Given this list of marker genes PIM3, MUC16, EPPK1, ADAM22, UBLCP1, SLC9B2, GPAM, MAPRE2, ATG3, PDPK1, SPRY4, GPR89B, S100A1, PJA2, PGAP1, CCND2, IZUMO1R, CYP11A1, GPM6B, SRSF12, FKBP7, GTF3C6, ZIM2, HSD17B7, SNTA1 (NCBI Gene Id 6640, syntrophin alpha 1), ABRAXAS2, IQCF1, GFI1, DMAC2L, MDH1, COPS7B, C4B, GPR22, NRIP3, MED7, SUCLG1, ERGIC2, DAD1, SLC36A4, TFAP2E, SOCS4, DMRTA2, IL31, JAM3, SLC38A10, RBP4, CEBPA, TMPRSS11E, TRPC6, AFP, ADAMTSL3, AKAP7, CPEB1, ALDH16A1, TMPRSS15 (NCBI Gene Id 5651), CCDC3, DAAM1, KYAT3, GATA3, APOBR, SWI5, MSANTD3, SERPINB9 (serpin family B member 9), MOAP1, CACNA1A, CEACAM20, SLC23A2 (NCBI Gene Id 9962), HSBP1, MLLT11, FAM167B, ZNF862, PRKCA, WDFY2, ARL5A, ZNF707, GBA1, CWC25, PPIC, SAMSN1, FTCD, OTOP2, ZNF169, SUGCT, MEX3B, ACBD7, RPL10, PRADC1, AQP9, TMT1B, ZFP2, TTC9C, ITGB3, PCDHA12, CST7, PIGT, TMCC1, TRPA1, NDFIP1, RDH10, ABHD17C, TMEM150A, LAMA5, ALDH1A1, PDGFD, TLCD3B, PSMD10, MTSS2, BABAM2, CLCA2, ASPRV1, NMNAT2, PRPSAP2, CDKN2C, CASKIN2, ZNF260, UMAD1, CD200R1, KANK1, ROCK2, SLC45A1, RAB9A, CCDC33, ATOH8, ARHGAP5, ASB2, SCAMP5, ASTN2, NLRP9, TFAP2A, JAG1, CGA, FERRY3, CACNG6, AOX1, CAB39, PEPD, RTN4, OPN1SW, NDUFA4L2, TTLL13 (NCBI Gene Id 440307), HNRNPH3, ARFGEF2, TENT5A, ADGRA3, CNR2 (NCBI Gene Id 1269), SRSF1, ZFYVE16, ETFB, LPIN2, ECM1 (NCBI Gene Id 1893), BMP2, MTMR6, CALCR, PLRG1, TFB1M, RNF152, C6orf89, PLXDC2, FAM156A, COG2, MMP15, CCDC117, TPD52L1, CD300LD, SH3RF3, PLCXD3 (phosphatidylinositol specific phospholipase C X domain containing 3), LCORL, HSD11B2, LAMP1, MUC20, GPR87, CSF1, PRAP1, HS3ST6, CEP128, NUDCD1, C9orf85, RIOK3, ZBTB24, NTS, IGSF1, GNAS, PALS1, BBS10, YIPF2, HDAC11, STPG4, ACCSL, NMB, GPR75, PPP1R3F, RAP2A (NCBI Gene Id 5911), AGPAT4, ISY1, MYO9A, PPP1R14D (NCBI Gene Id 54866), GRAP, PAFAH2, PDCD1LG2, here is a description of the gene set: species: Homo sapiens After activation, CD4+ helper T (Th) cells differentiate into distinct effector subsets. Although chemokine (C-X-C motif) receptor 5-expressing T follicular helper (Tfh) cells are important in humoral immunity, their developmental regulation is unclear. Here we show that Tfh cells had a distinct gene expression profile and developed in vivo independently of the Th1 or Th2 cell lineages. Tfh cell generation was regulated by ICOS ligand (ICOSL) expressed on B cells and was dependent on interleukin-21 (IL-21), IL-6, and signal transducer and activator of transcription 3. However, unlike Th17 cells, differentiation of Tfh cells did not require transforming growth factor b (TGF-b) or Th17-specific orphan nuclear receptors RORa and RORg in vivo. Finally, naive T cells activated in vitro in the presence of IL-21 but not TGF-b signaling preferentially acquired Tfh gene expression and promoted germinal-center reactions in vivo. This study thus demonstrates that Tfh is a distinct Th cell lineage. from publication Nurieva RI, Chung Y, Hwang D, Yang XO, Kang HS, Ma L, Wang YH, Watowich SS, Jetten AM, Tian Q, Dong C (PMID 18599325) Genes up-regulated in comparison of Th2 cells versus Th17 cells. Human Gene Set: GSE11924_TH2_VS_TH17_CD4_TCELL_UP